Given this list of marker genes Setmar, Terc, Ankrd31, Il6, Ubqln4, Slx4, Parn, Rps3, Ercc6, Ino80d, Rad51ap1, Exosc6, Brcc3dc, Pml, Brca1, Cdk1, Mbtd1, Npm2, Usp37, Dpf2, Ucn, Kcnk2, Trp53, Ccdc117, Eya4, Pagr1a, Eya2, Nat10, Arid1a, Gnl3l, Ptk2b (NCBI Gene Id 211703), Npm1, Bard1, Smc3, Endog, Nox4, Prkcq, Igfbp3, Hmgb1, Aicda, Stox1, Niban2, Ino80, Xrcc5 (X-ray repair complementing defective repair in Chinese hamster cells 5), Arid2, Taf9, Dek, Was (Wiskott-Aldrich syndrome), Paxip1, Cdkn1a, Axin2, Msh3, Ube2b, Fmn2, Mcidas, Gch1, Npas2, Cst3, Ankle1, Ankrd66, Pnp, Nek2, Baz1a, Pkib, Dach1, Parpbp, Rad50, Tex15, Rgcc, Ctnnb1, Taf5l, Helq, Taf5, Fbh1, Ing3, Ylpm1, Hras, Tnfsf4, Dffa, Fignl1, Ino80e, Arrb2, Tipin, Jade3, Vegfa, Abraxas1, Ticrr, Brcc3, Enpp7, Actl6b, Cbx8, Ppp4r3c2, Phf13, Timeless, Nudt16l1, Mrnip (MRN complex interacting protein), Epc2, Actr8, Ehmt2, Exosc3, Trrap, Taf12 (NCBI Gene Id 66464), Gtpbp4 (GTP binding protein 4), Ppp4r2, Dhx9, Zbtb38, H1f9, Zmpste24, Lpin1, Terf2ip, Nsd2, Tmem161a, Atad5, Tbx21, Shld1, Skp2, Acd, Riox1, Epc1, Apaf1, Hmbox1, Rbbp6, Peli1, Atxn7, Brd8, Dhx36, Tnfsf13 (tumor necrosis factor (ligand) superfamily, member 13), Taf6l, Cyp1b1, Mapk15, H1f2, Taf10, Rfc5, Esco1 (establishment of sister chromatid cohesion N-acetyltransferase 1), Pdgfa (platelet derived growth factor, alpha), Dkc1, Meaf6, Atxn7l3, Fbxo5, Top2b, Bmyc, Tfdp1, Crhr2, Wnt3a, Kmt5a, Tfpt, Smarcd3, Tent4b, Cyren, Stat6, Usp1, Hdac10, Smarcc2, Pinx1, H1f10 (H1.10 linker histone), Recql5, Babam2, Csnk2a1, Kmt5c, Cct5, Gfer, Mapk3, Nuggc (nuclear GTPase, germinal center associated), Rgn, Prkd2, Senp2, Brpf3, Ptprc, Anxa3, Ctc1, Rnf8, Wrap53, Fus, Smg6, Yeats4, Msh6, Pot1a, Polg2, Ndfip1, Smoc2, Bax, Cdt1, Pfn1, Hnrnpu, Ereg (NCBI Gene Id 269673), Cdc7, Dscc1, Uchl5, Chtf18, Uimc1, Sub1, Ahr, Supt7l, C3ar1, Dcp2, BC037156, Smarcd2, Kat2b, Atr, Kmt5b, Mtnap1, Src, Fh1, Hdgfl2, Mapk1, Vps72, Tfrc, Htr2a, Spidr, Jade1, Fgfr4 (fibroblast growth factor receptor 4), Ankrd1, Tada3, Hcrt, Wapl, Ube2v2, Slf2, E2f8 (E2F transcription factor 8), Trp53bp1, Chek1, Jun, Rnf126, Sh2b1, H1f6, Foxp3, Ep400, Gmnn, Usp51, Prkcg, Gja1, Dna2, Spire2, Pole3, Usp22, Nucks1, Pnkp, Aplf, H1f4, Ssbp1, Hnrnpa2b1, Foxm1, Jade2, Crebbp, Morf4l2, Kdm4d, Tnks2, Prkdc, Aurkb, Wrnip1, Rfc2, Obi1, H1f5, Ankrd17, Tada1, Myc, Ier3, Gli2, H1f1, Sirt6 (sirtuin 6), Ccna2, Zranb3, Eya3, Igf1r, Shld3, Tnf, Ppp4c, Fgf10, Wrn, Gmnc, Wiz, Smarcc1, Rad52, Supt20, Fancb, Pdgfb (NCBI Gene Id 18591), Il4, Smarca5, Mir181b-2, Nvl, Hnrnpd, Dusp1, Ercc8, Sgf29, Msh2, Nmnat1, Actl6a, Rad17, Gata5, Stn1, Cd28, Ino80b, Apbb1, Orc3, Cct8, Helb, H1f0, Ing4, Rnf169, Yy1, Stk19, Tinf2, Inppl1, Nfrkb, Ing5, Faf1, Bcl7a, Atrip, Map2k7, Spire1, Brd7, Hmces, Oga, Gnl3, Nppc, Mre11a, Exosc10, Potefam3a, Zfp365, Kat2a, Actb, Tnks, Parp3, Tigar, Cd40, Setd2, Bcl7b, Senp3, Ruvbl1, Terf2, Cdk9, Pot1b, Cdk2, Babam1, Rac1, Pdgfrb, Hsf1, Rtel1, Ino80c, Rpa2, Mettl4, Morf4l1, Gzma, Mapkapk5, Dbf4, Ddx39b, Smarcb1, Sirt1, Ppp1r10, Smarcad1, Prmt1, Gli1, Zcwpw1, Taf6, Plk1, Fgfr1, Cct6a, Ooep, Kat5, Esco2, Ten1 (NCBI Gene Id 69535), Fbxo4 (F-box protein 4), Cul4a, Mir181b-1, Polq, C1qbp, Atm, Dnajc2, Smarce1, Cidea, Smchd1, Rmi2, Mrgbp, Mad2l2, Cct2, Dpf3, Actr2, Bcl6, Pias4, Xrcc4, Eya1, Eny2, Ptges3, Mgmt, Rnf168, Dffb, Nek7, Mcrs1 (microspherule protein 1), Ppp4r3a, Atg7, Ilkap, Lig3, Rif1, Hnrnpc, Naf1, Slx1b, Cct3, Smarca4, Hmga2, Kctd13, Met, Cebpg, Tnfaip1, Nabp2, Khdc3, Rfc4, E2f7, Blm, Map3k4, Pif1, Aunip, Ppp4r3b, Tgfb1, Upf1, Lmna, Slf1, Pbrm1, Egf, Orc5, Camk2d, Fgf2 (fibroblast growth factor 2), Cacybp, H1f8, Smg1, Cct7, Kdm1a, Ciz1, Abl1, Id3, Mapk8, Potefam3b, Nbn, Klhl15, Cct4, Il2, Ifng (NCBI Gene Id 15978), Otub1, Cgas, Gsk3b, Prkcd, Ercc2, Taf7, Sf3b5, Tspyl2, Ercc4, Rad51, Hgf, Atf1, Il27ra, Clcf1, Egfr, Taf2, Bcl7c, Trim28, Dpf1, Kat7, Parp1, Ruvbl2, Rad18, Ddx11, Setd7, Klf4, Hdac8, Cdkn2a, Ppp4r3c1, Terf1, Zscan4c, Actr5, Map2k4, Tcp1, Ttf1, Ube2n, Chrac1, Xrcc1, Slc15a4, Aifm1, Shld2, Rfc3, Radx, Nfatc1, Dmap1, Pak3, Prdm9, Adipoq, Mlh1, Phf10, Smg5, Twist1, Cdc42, Ercc1, Ager, Suv39h1, H1f3, Fam168a, Parg, Mpv17, Sf3b3, Pds5a, Smarca2, Akt1, Supt6, Chtf8, Pcna, Sirt7, Wdr48, Mas1, Ogg1, Atrx, Smarcd1, Dynll1, Pms2, here is a description of the gene set: Mouse Gene Set: GOBP_REGULATION_OF_DNA_METABOLIC_PROCESS species: Mus musculus Any process that modulates the frequency, rate or extent of the chemical reactions and pathways involving DNA.